The following is a description of a gene set: studied in species Mus musculus The covalent alteration of one or more nucleotides within a tRNA molecule to produce a tRNA molecule with a sequence that differs from that coded genetically. Mouse Gene Set: GOBP_TRNA_MODIFICATION, and this is the list of marker genes: Kti12 (KTI12 homolog, chromatin associated), Mto1, Osgep, Elp1 (elongator complex protein 1), Tyw5, Trmt10c, Trmt12 (tRNA methyltransferase 12), Tyw1, Gon7, Trmt112, Sars1, Elp5, Pus3, Mocs3, Nsun6, Pusl1, Elp2, Pus1, Nsun3 (NOL1/NOP2/Sun domain family member 3), Trmt13, Trmt10a, Trmt61a, Trmu, Trub1, Alkbh1, Trmt1l, Elp4, Trmt1, Pus7, B3gntl1, Dus1l, Aars1, Trmt44, Mettl8, Tyw3, Wdr4, Rpusd4, Thumpd3, Mettl6, Qtrt1, Trmo, Nsun4, Gtpbp3, Trmt5, Trdmt1, Dus3l, Yrdc, Bcdin3d, Elp6, Cdk5rap1, Dtwd2, Tprkb, Dalrd3, Nsun2, Cdkal1, Osgepl1, Urm1, Ctu2, Pus10, Thg1l, Elp3, Lcmt2, Thada, Trit1, Dtwd1, Wdr6, Tarbp1, Qtrt2, Ankrd16, Dph3, Mettl2, Qng1, Mettl1, Trmt6, Hsd17b10, Gtdc1 (NCBI Gene Id 227835), Trmt9b, Mtfmt, Nat10, Dus4l, Trmt10b, Adat2, Ctu1, Sepsecs, Thumpd2, Dus2, Ftsj1 (FtsJ RNA 2'-O-methyltransferase 1), Akt1, Alkbh8, Thumpd1